The following is a description of a gene set: Neighborhood of PPP2R4 Human Gene Set: MORF_PPP2R4 studied in species Homo sapiens Neighborhood of PPP2R4 protein phosphatase 2A, regulatory subunit B' (PR 53) in the MORF expression compendium, and this is the list of marker genes: UQCRB, TMBIM6, NME2, PTPA, TMED10, CNIH1, AP2M1, NDUFA1, TSR3, NEDD8, RAD23B, UBA1, PSMB4, HSBP1, BANF1, EIF4E2, URM1, EIF2B2, PSMD8, CFDP1, YWHAB, BUD31 (NCBI Gene Id 8896), TBCA, PSMC4, BBLN, CDIPT, RER1, NDUFB1, POLR2H, ATP5MF, VTI1B, CAPNS1, ETFA, VCP, CNPY2, TMED2, SPTLC1, ELOB (elongin B), TMEM147, PPP1R7, ATOX1, VPS72, PSMC3, MORF4L2, PDCD6, PRMT1, SIVA1, PSMB5, TM9SF1, SLC25A1, PSMC1